The following is a description of a gene set: Pathway Definition from KEGG: Ca2+(cyto) == CALM == (CAV,RYR) Human Gene Set: KEGG_MEDICUS_REFERENCE_CA2_CAM_VGCC_RYR_SIGNALING_PATHWAY Ca2+/CAM-VGCC/RYR signaling pathway. Pathway ID: N01649. Pathway type: Reference. Pathway class: nt06528 Calcium signaling. species: Homo sapiens, and this is the list of marker genes: CACNA1S, RYR2, RYR1, CALM2, CALM1, CACNA1C, CALM3, CACNA1B, RYR3, CACNA1E, CACNA1A